The following is a description of a gene set: from publication Ramilo O, Allman W, Chung W, Mejias A, Ardura M, Glaser C, Wittkowski KM, Piqueras B, Banchereau J, Palucka AK, Chaussabel D (PMID 17105821) Each infectious agent represents a unique combination of pathogen-associated molecular patterns that interact with specific pattern-recognition receptors expressed on immune cells. Therefore, we surmised that the blood immune cells of individuals with different infections might bear discriminative transcriptional signatures. Gene expression profiles were obtained for 131 peripheral blood samples from pediatric patients with acute infections caused by influenza A virus, Gram-negative (Escherichia coli) or Gram-positive (Staphylococcus aureus and Streptococcus pneumoniae) bacteria. Thirty-five genes were identified that best discriminate patients with influenza A virus infection from patients with either E coli or S pneumoniae infection. These genes classified with 95% accuracy (35 of 37 samples) an independent set of patients with either influenza A, E coli, or S pneumoniae infection. A different signature discriminated patients with E coli versus S aureus infections with 85% accuracy (34 of 40). Furthermore, distinctive gene expression patterns were observed in patients presenting with respiratory infections of different etiologies. Thus, microarray analyses of patient peripheral blood leukocytes might assist in the differential diagnosis of infectious diseases. studied in species Homo sapiens Human Gene Set: GSE6269_HEALTHY_VS_E_COLI_INF_PBMC_DN Genes down-regulated in comparison of peripheral blood mononuclear cells (PBMC) from healthy donors versus PBMC from patients with acute E. coli infection., and this is the list of marker genes: CDC42, FUT6, PPIL2, SDCBP, HBG1, TAGLN2, ZNF3, OLFM1, ADM, YPEL5, HSPA13, C8B, KIAA1549L (NCBI Gene Id 25758), DLC1, SASH1, EPHB2, CORO1B, DNAH17 (NCBI Gene Id 8632), COX5AP1, RNASE3, PCDH7, SRD5A1, UQCRFS1, CLGN, PLAUR, CXCL2, MKI67, FEM1B, LIM2, SIRPAP1, IRAK3, TTYH1, TET3, PDE4D, TRIM25, RIPK2, PTP4A1, REG1B (NCBI Gene Id 5968), PRR15L, GPX2, PRTN3, RPL21P2, FKBP1A, ARNT, CEACAM6, AMPH, VDAC1P6, KLK12 (kallikrein related peptidase 12), CADM3-AS1, MIR22HG, KAZN, MAPRE1, MYL11, EPM2A-DT, KLHL29, STK17B, CD44, SPINT3, SLC6A2, PTGIR, CHD2, ANGPTL2 (angiopoietin like 2), SPINK1, CACNA1D, SULT1B1, FAM124B, BNIP3L, DBH, BACH1, HBA1, BTG3, TSPAN6, ZMYM5, MPP2, TEC, DESI1, MCL1, SUSD4, TUBA1A, ELANE, CNR1, GK, DIO2, SAMD4A, DDC, GLUL, NPL, HPGD, DEFA1, H1-0, APH1B, CYBB, CDH20, DYSF, DAZAP2, HOXA9, FTH1, COL4A5, POTEKP, ST7L, PLXNB1, MXD1 (MAX dimerization protein 1), MPO, RCN3, EPB41L1, ESR1, LAMA4, TBX19, RAB20, SLC35F6, ETV5, SULT1E1, FOLH1, SCGB1D2, PRSS3, BPI, IGF2BP3, FCGR1A, TRAPPC9, CCDC30, MELTF, PLBD1, PLEK (pleckstrin), RFX3, CCL22, CYP3A4, RARB, FEZF2 (NCBI Gene Id 94016), ZXDA, PKD1L1-AS1 (PKD1L1 antisense RNA 1), HIF1A, LRP6, PAK4 (NCBI Gene Id 115291), SLC22A4, UBE2D3, COL9A3, DOCK6, FGF18, ZFAND5, MAX, KRT75, F7, MC2R, WWP2, CRYAB, SERPINB1, CDX4, AOC1, CALCA, DUTP1, SEMA5A, MSN, IGLVIVOR22-1, DUSP3, DEPP1, REEP1, LINC00115, TNFAIP1, LHX3, PRR3, DIAPH2, GDF5, SUMO3, CTIF, ENSG00000248161, PFKFB3, BMP5, HAND1, CXCL8, SOD2, SORT1, DDIT3, LMCD1